Given this list of marker genes Rab1a, Ap1s3, Vps33b, Acrbp, Abcg1, Pafah1b1, Osbp, Hid1, Hps4, Agfg2, Baiap3, AU040320, Izumo3, Rab38, Ap1b1, Garin1a, Cylc2, Sec23ip, Slc9a8, Ap3b1, Tmf1, Hps5, Garin3, Ap1s2, Agfg1, Ptbp1, Ap1g1, Pfn4, Ap3s2, Ccdc38, Pdcl2, Abca1, Zpbp2, Snx19, Ap3d1, Ap1m1, Dtnbp1, Aqp1, Dcaf17, Zpbp, Creb1, Pln, Zfp385a, Chn2, Lyst, Eqtn, Mta1, Cylc1 (NCBI Gene Id 67407), Fsip1, Ap3m1, Tbpl1, Poc1b, Hps6, Rfx2, Nectin2, Kcne1, Pla2g3, Sox30, Ap1s1, Slc35d3, Serpine2 (serine (or cysteine) peptidase inhibitor, clade E, member 2), Nbeal2, Spaca1, Sppl2c, Mfsd14a, Vps13b, Hps1, Ccdc136, Syt4, Actl7a, Tbc1d20, Hps3, Tmprss12, Srgn, Spink2, Ap3s1, Actl9, Ccdc42, Garin1b, Bloc1s3, Fam209, here is a description of the gene set: species: Mus musculus Mouse Gene Set: GOBP_SECRETORY_GRANULE_ORGANIZATION A process that is carried out at the cellular level which results in the assembly, arrangement of constituent parts, or disassembly of a secretory granule. A secretory granule is a small subcellular vesicle, surrounded by a membrane, that is formed from the Golgi apparatus and contains a highly concentrated protein destined for secretion.